The following is a description of a gene set: Th1 and Th2 cells arise from a common precursor cell in response to triggering through the TCR and cytokine receptors for IL-12 or IL-4. This leads to activation of complex signaling pathways, which are not known in detail. Disturbances in the balance between type 1 and type 2 responses can lead to certain immune-mediated diseases. Thus, it is important to understand how Th1 and Th2 cells are generated. To clarify the mechanisms as to how IL-12 and IL-4 induce Th1 and Th2 differentiation and how TGF-beta can inhibit this process, we have used oligonucleotide arrays to examine the early polarization of Th1 and Th2 cells in the presence and absence of TGF-beta after 0, 2, 6 and 48 hours of polarization. Human Gene Set: GSE2770_TGFB_AND_IL4_VS_TGFB_AND_IL12_TREATED_ACT_CD4_TCELL_48H_DN Genes down-regulated in CD4 T cells activated by anti-CD3 and anti-CD28: TGFB1 and IL4 (48h) versus TGFB1 and IL-12 (48h). from publication Lund R, Aittokallio T, Nevalainen O, Lahesmaa R (PMID 14607935) species: Homo sapiens, and this is the list of marker genes: CPNE3, NREP, PTPN18, OGFOD3, CHRAC1, PPT1, GGTA1, TMC8, MAPRE2, CMIP, PEBP1, GCNT1, SAT2, MAPK8IP3, TNFSF10, LSM14A, MAP4K1, RERE, SIN3B, ALDH3B1, TMEM170B, FAF1, NDST1, PGP, NR4A1, HMGB2, PIGL, RPS6KA4, ENSG00000237250, TMEM14C, ASGR2, REPS2, SIGLEC16, VAV2, INPP5K, LCTL, KAT2A, CLEC11A, PPIL3, ORMDL1, ITGA4, MTHFD1, ZFP91, TMEM119, NDRG3, PRKX, TAPBPL, RPH3A, CIDEB, FNTB, STX16, NRGN, GSDMD, DCPS, DGKD, CAMK2G, TPBGL, ZNF91, FAM118A, TSHZ1, SART1, NUP210, GSE1, KBTBD11, VEGFA, LIN7A, DCXR, AKT1, FLI1 (Fli-1 proto-oncogene, ETS transcription factor), MMP25, ACCS, PTPN22, PRKAR2B, WDFY2, PEG3, SELENON, IGFBP7, ANP32A, GIMAP2, PSTPIP1, GPBAR1, CAMK2D, FAM228B, PDK3, PCIF1, PRPS2, MPC1, LTA4H, TBC1D4, GPR160, GDI2, PTEN, TOX2, TKT, LINC00528, ARPIN, GALK2, INO80E, THUMPD2, R3HDM1, LAMTOR1, C6orf58, FAM53B, SLC25A35, LRP5L, EIF2AK1, CSF3R, PTGER2, MLST8, RNF126P1, DPYSL2, ERI3, MSRB2, HEXA, MRPL48, SIGIRR, HDDC3, UBTF, NAPSB, JUP, GPS1, CHPT1, LMAN1, DENND1C, CLEC4G (NCBI Gene Id 339390), KLF7, ADAMTSL4, TLE3, MPPE1, AKAP8, LENG8, BCKDHA, ZNF185, ILF3-DT, CHN2, C11orf21, NPY2R, CAPZB, TMT1A, SUMF2, SNTB1, MTX1, COQ8A, PRSS16 (serine protease 16), BPI, SNX17, SF1, RASGRP2, TACC3, DNMT3A, LAS1L, NR4A3, REX1BD, NEDD8, LRMDA, VAMP5, MBOAT1, ARSJ, ELF3, SLC9A9, RAB3D (RAB3D, member RAS oncogene family), ARMH1, HNRNPDL, STX10, CAPNS1, MTMR11, FAM204A, VSIG4, ZBED10P, DCTN3, ADD3, ANO8, GOLM1, S1PR3, ALAD, ABHD14B, C1QC, FAM216A, POLB (NCBI Gene Id 5423), SLC18B1, ZNF395, CTSO, CCDC88C, MIF4GD, ZNF865, ICAM2, PRAF2, ILDR1, MIDEAS, NUP93, KICS2, ASB13, WAS (NCBI Gene Id 7454), H2AJ, TMEM39B, TESC